Given this list of marker genes Ssx2ip, Pcm1, Ift81, Dync2li1, Ift56, Ift74, Cep131, here is a description of the gene set: Mouse Gene Set: GOBP_INTRACILIARY_TRANSPORT_INVOLVED_IN_CILIUM_ASSEMBLY The bidirectional movement of large protein complexes along microtubules within a cilium that contributes to cilium assembly. studied in species Mus musculus